Given this list of marker genes RPL34, PBX3, RPL10A, CNR1 (cannabinoid receptor 1), COL3A1, TMSB15A, FIG4, RPS11, ELAVL4, LMO4, COL1A2, LTBP2, BCL2, RPS17, TPT1, NTRK3, RND3, MYCN, CCND3, IRF8, RPL9P7, EEF1B2, RPL7, TFDP2, IGF2, VCAN, RPL21, UCHL1, PTCH1, NID1, GCNT2, RPL24, APOD, CXCR4, RPS18, QSOX1, RPL35A, INSM1, TCF4, SCG5, RPS10, TCF12, LAMC1, RPS23, CYFIP1, GLI1, RPS29, COL1A1, CFH, NDP, RPL36A, NHLH1, C1S, NFATC4, MGP (NCBI Gene Id 4256), SHROOM2, NFATC3, ALDH1A3, RPL39 (NCBI Gene Id 6170), IGFBP5, NMU, here is a description of the gene set: from publication Pomeroy SL, Tamayo P, Gaasenbeek M, Sturla LM, Angelo M, McLaughlin ME, Kim JY, Goumnerova LC, Black PM, Lau C, Allen JC, Zagzag D, Olson JM, Curran T, Wetmore C, Biegel JA, Poggio T, Mukherjee S, Rifkin R, Califano A, Stolovitzky G, Louis DN, Mesirov JP, Lander ES, Golub TR (PMID 11807556) Human Gene Set: POMEROY_MEDULLOBLASTOMA_DESMOPLASIC_VS_CLASSIC_DN Top down-regulated marker genes for medulloblastoma classification: desmoplastic vs classic morphology. Embryonal tumours of the central nervous system (CNS) represent a heterogeneous group of tumours about which little is known biologically, and whose diagnosis, on the basis of morphologic appearance alone, is controversial. Medulloblastomas, for example, are the most common malignant brain tumour of childhood, but their pathogenesis is unknown, their relationship to other embryonal CNS tumours is debated, and patients' response to therapy is difficult to predict. We approached these problems by developing a classification system based on DNA microarray gene expression data derived from 99 patient samples. Here we demonstrate that medulloblastomas are molecularly distinct from other brain tumours including primitive neuroectodermal tumours (PNETs), atypical teratoid/rhabdoid tumours (AT/RTs) and malignant gliomas. Previously unrecognized evidence supporting the derivation of medulloblastomas from cerebellar granule cells through activation of the Sonic Hedgehog (SHH) pathway was also revealed. We show further that the clinical outcome of children with medulloblastomas is highly predictable on the basis of the gene expression profiles of their tumours at diagnosis. species: Homo sapiens